The following is a description of a gene set: Neutrophils play critical roles in modulating the immune response. However, neutrophils have a short circulating half life, are readily stimulated in vitro, and have low levels of cellular mRNA when compared to other blood leukocyte populations. All of these factors have made it difficult to evaluate neutrophils from clinical populations for molecular and functional studies. Here we present a robust methodology for rapidly isolating neutrophils directly from whole blood and develop ‘on- chip’ processing for mRNA and protein isolation for genomics and proteomics. We validate this device with an ex vivo stimulation experiment and demonstrate the ability of the device to discriminate subtle differences in the genomic and proteomic response of peripheral blood neutrophils to direct and indirect stimulation. Lastly, we implement this tool as part of a near patient blood processing system within a multi-center clinical study of the immune response to severe trauma and burn injury and demonstrate that this technique is easy to use by nurses and technical staff yielding excellent quality and sufficient quantity of mRNA for sensitive genomic readout of the host response to injury from publication Kotz KT, Xiao W, Miller-Graziano C, Qian WJ, Russom A, Warner EA, Moldawer LL, De A, Bankey PE, Petritis BO, Camp DG 2nd, Rosenbach AE, Goverman J, Fagan SP, Brownstein BH, Irimia D, Xu W, Wilhelmy J, Mindrinos MN, Smith RD, Davis RW, Tompkins RG, Toner M, Inflammation and the Host Response to Injury Collaborative Research Program (PMID 20802500) Genes up-regulated in neutrophils: untreated versus LPS. species: Homo sapiens Human Gene Set: GSE22103_UNSTIM_VS_LPS_STIM_NEUTROPHIL_UP, and this is the list of marker genes: IWS1, RARA, TRIB1, RASGEF1B, IRF4, EIF1B, NFIC, NOL10, NIP7, DEF6, RNF11, BEND3, SKIL, ZBTB21, SEC22A, PPP2CA, LFNG, TNFAIP2, MLLT6, PRELID3B (PRELI domain containing 3B), AKAP1 (A-kinase anchoring protein 1), PRMT6, CD40, MMADHC, TUBB6, NUP35, YEATS4, PHLDA1, BCL3, KLF16, OTUD4, FOXJ3, CDK13, SPIN4 (NCBI Gene Id 139886), ABI3, ZFP36L1, NIBAN2, SMCR8, PDGFB, BDP1, MRPL17, RIOX2, ITGA5, GFER, SUSD6, MAX, PIM3, FBXL14, CCDC71, GRIPAP1, RGS1, GPATCH2L (G-patch domain containing 2 like), ARCN1, PRDM2, THEMIS2, PSMG3, RHOC, WDR75, IMP3, SEMA4D, MFSD5, KLHL9, ADAM8, PTPN9, ERCC1, MBLAC1, ABHD2, NRF1, DDIT3, ZEB1, NSMF, KLHL26, HIVEP1 (HIVEP zinc finger 1), FAIM, FAS, EXOSC3, IFNAR1, HAPLN3, CRTC2, TRMT61A, NECAP1, LRFN4, DCP1A, MAGOHB, LSM12, MMP12, OVCA2, DDX51, CAMK2N2, USP42, OSGIN1 (NCBI Gene Id 29948), TRAF3, AMY2A, HBS1L, MFHAS1, OPTN, RELA, ZNF282, DNAJC30, C8orf33, IL4R, IL7R, DCSTAMP, FNBP1, RBSN, INTS6, ZNF280C, ITPKC, BAG5 (NCBI Gene Id 9529), THUMPD1, MAP2K4, MORF4L1, AEN, RABGGTB, PTX3, CEBPA, GNA13, C7orf25, GTPBP4, RPS19BP1, ARPC5L, IRF2BPL, ST6GALNAC4, CCDC90B, RGP1, ASB2, JUNB, PRR13, VASP, MRPL22, WDR1, NPLOC4, ERRFI1, PPP1R16B, PIK3R5, SOCS5, PIGY, TIMM10, TP53RK, BRWD1, BET1L, BBS5, NSMCE3, CRK, CDC34, PHRF1, ANXA5, ZDHHC18, ARFGAP3, NAA16, NR1H2, UBXN4, ZKSCAN8, ATF1, RDH13, CTU1, AMZ2, ANKRD39, MRPS18B, RHOG, CLK3 (NCBI Gene Id 1198), UBOX5, NSRP1, MARK4, ZNF841, PIP5K1C, RPP25L, OTULIN, BCL2A1, NINJ1, ANAPC4, FANCF, ICAM1, HS6ST1, SH3PXD2B, TUBA1A, AOPEP, HIVEP3, TAF1A, NFE2L2, SECISBP2, SENP3, RNASEH1, KIF2A, PPP1R15B, ZBTB39, NUB1, PABIR1, ZNF639, IPO7, AQR, MAPKAPK3, SF3A2, UBE2I, SETD5, KCNN4, ZFP64, ELAC2, SLC7A1, SDHAF1